Given this list of marker genes AGO1, AGO2, TSNAX, AGO3, TARBP2 (NCBI Gene Id 6895), TSN, AGO4, PRKRA (NCBI Gene Id 94716), DICER1, here is a description of the gene set: species: Homo sapiens part of: Gene Silencing by RNA Reactome Pathway: Small interfering RNA (siRNA) biogenesis Small interfering RNAs (siRNAs) are 21-25 nucleotide single-stranded RNAs produced by cleavage of longer double-stranded RNAs by the enzyme DICER1 within the RISC loading complex containing DICER1, an Argonaute protein, and either TARBP2 or PRKRA (PACT). Typically the long double-stranded substrates originate from viruses or repetitive elements in the genome and the two strands of the substrate are exactly complementary.<br>After cleavage by DICER1 the 21-25 nucleotide double-stranded product is loaded into an Argonuate protein (humans contain 4 Argonautes) and rendered single-stranded by a mechanism that is not well characterized.<br>siRNA-loaded AGO2 is predominantly located at the cytosolic face of the rough endoplasmic reticulum and has also been observed in the nucleus.